Given this list of marker genes PBK, PLP2, CERCAM, CCNF, ATP5IF1, DUSP14, KIF11, CTLA4, GSTM5, SKA1, RAD51AP1 (RAD51 associated protein 1), E2F8, E2F7, MYBL2 (MYB proto-oncogene like 2), IL1R2, CFAP91, GZMA, NATD1, ALDH7A1, PKN3, PAICS (NCBI Gene Id 647765), FANCD2, CIT, SPC25, KIF2C, PLEKHO1, C12orf75, ALG6, KIF20A, IFI44, CHEK1, DYNLT5, CEBPA, CENPI, NDRG1, CCDC18, DEPDC1B, IL21, ALAD, MELK, MX2, CDC25C, E2F3, PRR11, KPNA2, TG, RPS27L, UBE2C, COQ8A, PSMD12, LGALS1, LRR1, CDCA5, GEN1, EHD4, GMPS, TKFC, YBX3, CCNB2, MCM10, TUBG1, ANLN, AHCY, SAP30, PRELID3B, BIRC5, TPX2, NDUFAF2, RBM44, SCCPDH, EGR2, DDIAS, BLMH, STIL, RACGAP1, LSM6, NUF2, PTGR1, SPOCK2, TRIP13, ATMIN, PPP1R14C, FAH, MYL4, DNA2, UHRF1 (ubiquitin like with PHD and ring finger domains 1), AP3B1, PERP (NCBI Gene Id 64065), MX1, TICRR, FAM81A, COX7A2, WARS1, SPATS2, ISG20, SNRPA, ESD, MMS22L, FABP5, DHFR, LAG3, ESM1 (endothelial cell specific molecule 1), XYLB, DGKG, DTL, CKAP2, NEK2, TNS1, PCLAF (NCBI Gene Id 9768), CYP11A1, LUZP1, TRAM2, ADAM19, AURKA, MND1, IL22, PDCD1LG2, CACNA1D, TOP2A, ERMN, CNIH4, IRAG2, NUDT4, POC1A, POU2F2, KIF18B, XIAP, SGO1, TTK, KIF22, CA13, LIG1, BUB1, AKAP6, AKR1B15, PLXDC2, CENPE, ARHGAP19, LGALS3, CCNE1, SLC66A3, HHEX, CLSPN, SLBP, INTS13, MVB12A, CKS1B, NEURL1B, FOXM1, TARS3, NUSAP1, DNASE1L3 (NCBI Gene Id 1776), FIGNL1, PLK1, PLXDC1, CDKN1A, CXCR5, ARPC1A, IL4 (NCBI Gene Id 3565), MYO1C, CDK1, CDC20, PLAC8, NPNT, PNPO, TPI1, NACC1 (NCBI Gene Id 112939), DPAGT1, ZBTB32, H2BC5, HIVEP3, IL1RL1, RECQL4, PXMP2 (NCBI Gene Id 5827), FEN1, ZEB2, IFT43, CCNA2, PARPBP, ESCO2, STMN1, IKZF3, SKA3, FBXO44, MFSD2A, GZMB, CDKN2C, CEP55, ZFPM1, CENPF, GMNN, KIF4A, CDC6, FAM72A, LRRC42, SPC24, PLOD2, ASPM, SHCBP1, EXO1, here is a description of the gene set: Human Gene Set: GSE39110_DAY3_VS_DAY6_POST_IMMUNIZATION_CD8_TCELL_DN from publication Castro I, Dee MJ, Malek TR (PMID 23018461) Much is known concerning the cellular and molecular basis for CD8+ T memory immune responses. Nevertheless, conditions that selectively support memory generation have remained elusive. Here we show that an immunization regimen that delivers TCR signals through a defined antigenic peptide, inflammatory signals through LPS, and growth and differentiation signals through the IL-2R initially favors antigen-specific CD8+ T cells to rapidly and substantially develop into tissue-residing T effector-memory cells by TCR transgenic OVA-specific OT-I CD8+ T cells. Amplified CD8+ T memory development depends upon a critical frequency of antigen-specific T cells and direct responsiveness to IL-2. A homologous prime-boost immunization protocol with transiently enhanced IL-2R signaling in normal mice led to persistent polyclonal antigen-specific CD8+ T cells that supported protective immunity to Listeria monocytogenes. These results identify a general approach for amplified T memory development that may be useful to optimize vaccines aimed at generating robust cell-mediated immunity. Gene expression analysis was performed for OT-I T cells on day 3 and day 5 after activation with ovalbumin and LPS in vivo with and without treatment with IL-2 using an agonists IL-2/anti-IL-2 complexes (IL2/Jes-6.1) species: Homo sapiens Genes down-regulated in CD8 T cells after immunization: day 3 versus day 6.